The following is a description of a gene set: C-Jun NH2 terminal kinases (JNKs) are an evolutionarily conserved family of serine/threonine protein kinases, that belong to mitogen activated protein kinase family (MAPKs - also known as stress-activated protein kinases, SAPKs). The JNK pathway is activated by heat shock, or inflammatory cytokines, or UV radiation. <p>The JNKs are encoded by at least three genes: JNK1/SAPK-gamma, JNK2/SAPK-alpha and JNK3/ SAPK-beta. The first two are ubiquitously expressed, whereas the JNK3 protein is found mainly in brain and to a lesser extent in heart and testes. As a result of alternative gene splicing all cells express distinct active forms of JNK from 46 to 55 kDa in size. Sequence alignment of these different products shows homologies of >80%. In spite of this similarity, the multiple JNK isoforms differ in their ability to bind and phosphorylate different target proteins, thus leading to the distinctive cellular processes: induction of apoptosis, or enhancment of cell survival, or proliferation.<p>Activation of JNKs is mediated by activated TAK1 which phosphorylates two dual specificity enzymes MKK4 (MAPK kinase 4) and MKK7(MAPK kinase 7). part of: MAP kinase activation species: Homo sapiens Reactome Pathway: JNK (c-Jun kinases) phosphorylation and  activation mediated by activated human TAK1, and this is the list of marker genes: TAB2, NOD2, NOD1, RPS27A, UBC, TAB1, MAP3K7, MAPK9, TRAF6, UBE2N, UBE2V1, MAPK8, IRAK2, MAP2K7, IRAK1, RIPK2, MAP2K4, UBB, TAB3, MAPK10, IKBKG, UBA52